Given this list of marker genes APCS, IFITM3, TRIM10, TRIM5, MID2, TMEFF1, FCN1, CD74, FCN3, TRIM11, SNX3, CIITA, LY6E, TRIM26, TRIM25, TRIM59, PTX3, IFITM2, GSN, LRRC15, TRIM8, IFNA2, TRIM31, IFITM1 (interferon induced transmembrane protein 1), here is a description of the gene set: A process in which a host inhibits or disrupts the entry of a symbiont into a host cell. species: Homo sapiens Human Gene Set: GOBP_HOST_MEDIATED_SUPPRESSION_OF_SYMBIONT_INVASION